Given this list of marker genes LMNA, LGALS3BP (NCBI Gene Id 3959), MCTP1, AQP9, TRGC1, TYMP, PLAUR, FGL2, LTBP1, C3AR1, CHST15, C1QB, IFI30, PELI1, RASGRP3, FBP1, PRKAR2B, SELENOP, FCN1, HOXA4, CYP1B1, CD300C (NCBI Gene Id 10871), SERPINA1, HNMT, TNFAIP3, SCO2, CASP1, HIP1, IGF2R, SLC15A3, CXCL2, CAT, SLC16A3, IL1B, FCGR2A, PF4, CLU, NINJ1, MARCKS, BEX3, QPRT, COL4A5 (collagen type IV alpha 5 chain), H2BC21, S100A6, FGR, CD163, H2AC18, HK3, TMEM176B, SAT1, HOXA9, CCL20, CXCL10, WARS1, PTAFR, AIM2, TNF, JAG1, BASP1 (NCBI Gene Id 10409), TMEM176A (transmembrane protein 176A), ABCC4, GNS, CCL4, RUNX1, HMOX1, SMPDL3A, CCL23, H1-2 (NCBI Gene Id 3006), SERPINB2, GCH1, SOD2, H2BC4, KCNJ2, FTO, C1QA, MAFB, MVP, LILRB1, HCK (NCBI Gene Id 3055), PLA2G4A, HOXB2, PLS1, CAMK1, NAP1L1, HCAR3, HOXB6, PTX3, CD14 (CD14 molecule), FOXC1, CCL3, DPEP2, SLC2A6, LILRA3, MEIS1, SMC4, SORT1, BCL6, CTSD, SNCAIP, CPVL, IL6, APOBEC3A, C5AR1 (NCBI Gene Id 728), HOXB3, HOXA6, HOXB5, PIEZO2, CTSG, TRIB1, TLR4, NFKBIA, ITGB3, HOXA7, PHKA2, LILRB3, EPB41L3, H3C4, GDF15, BCL2A1, ADCY2, TNFSF10, ABHD2 (NCBI Gene Id 654057), PILRA, G0S2, CARD9, PRKCD, THBS1, CD36, VCAN, NAMPT, TBXAS1, ADGRE1, HOMER3, HOXA5, PPBP, STS, PBX3 (PBX homeobox 3), LILRA5, IRX5, CTSL, PRDM2, AKR1C1, LAPTM4B, PLEK, VNN1, ARHGAP22, PDGFD, SMCO4, LILRB2, SCPEP1, TREM1, CCL1, TRIM16, MMP2, FCGR3B, CX3CR1, CD86, DEFB1, SNX10, SCHIP1, RNASE2CP, TNFAIP2, VNN2, FCGR3A, IER3, FPR1, ACSL1, GGT1, H3C10, KCNK5, DMXL2, TTC27, LGALS2, EREG, ETS2, RHAG, NFKB2, C2, TCIRG1, CCR1, HOXA10, LILRA1, CAST, SECTM1, NCF1, SPINK2, CXCL3, here is a description of the gene set: from publication Verhaak RG, Goudswaard CS, van Putten W, Bijl MA, Sanders MA, Hugens W, Uitterlinden AG, Erpelinck CA, Delwel R, Löwenberg B, Valk PJ (PMID 16109776) Mutations in nucleophosmin NPM1 are the most frequent acquired molecular abnormalities in acute myeloid leukemia (AML). We determined the NPM1 mutation status in a clinically and molecularly well-characterized patient cohort of 275 patients with newly diagnosed AML by denaturing high-performance liquid chromatography (dHPLC). We show that NPM1 mutations are significantly underrepresented in patients younger than 35 years. NPM1 mutations positively correlate with AML with high white blood cell counts, normal karyotypes, and fms-like tyrosine kinase-3 gene (FLT3) internal tandem duplication (ITD) mutations. NPM1 mutations associate inversely with the occurrence of CCAAT/enhancer-binding protein-alpha (CEBPA) and NRAS mutations. With respect to gene expression profiling, we show that AML cases with an NPM1 mutation cluster in specific subtypes of AML with previously established gene expression signatures, are highly associated with a homeobox gene-specific expression signature, and can be predicted with high accuracy. We demonstrate that patients with intermediate cytogenetic risk AML without FLT3 ITD mutations but with NPM1 mutations have a significantly better overall survival (OS) and event-free survival (EFS) than those without NPM1 mutations. Finally, in multivariable analysis NPM1 mutations express independent favorable prognostic value with regard to OS, EFS, and disease-free survival (DFS). Genes up-regulated in acute myeloid leukemia (AML) patients with mutated NPM1. species: Homo sapiens Human Gene Set: VERHAAK_AML_WITH_NPM1_MUTATED_UP